Given this list of marker genes WDR24, PLEKHG1, SLX9, RNF111, PLEKHG3, RASA1, UBE3A, RNF115 (ring finger protein 115), H3C4, DCAF17, BRAF, STK26, C2CD3, ARMC7, EMP3, CTDSP2, ADNP, RASGRP2, ABRAXAS2, CTPS2, UNKL, HYCC1, SORL1, KIF3B, ACAP2, SLC2A9, SNRK, PAN2, ARL8B, PGM2L1, PRPSAP1, KRR1, CASP2, PLOD3, PKNOX1, PDE8A, PKN2, HMG20A, SORD, GPR160, TACC1, IKBKE, NFKB1, NKAPD1, ZCCHC8, NAA16, SLC29A3, LATS2, CMPK1, MRPS31, MSANTD4, MON2, TERF2, ATXN7L3B (NCBI Gene Id 552889), WLS, PIAS3, ALAS1, AGFG1, VIRMA, TMEM245, KHDC4, RNF216, ABHD14B, BRWD3, SREK1, CD300LB, HIPK3, PKD2, ERLIN2, NEK7, MAST3, RELCH, PREX1, MST1R, RERE, DENND5A, MFAP1, HEATR5B, CCDC71L, CYFIP1, PGD, SRCAP, ASH1L, HMGXB4 (HMG-box containing 4), IQGAP2, ZNF414, ANKRD40, MINDY1, DEPTOR, TTI2, TTC14, RSRC1, APP, KLHDC10, PLEKHH3, TPM3, ZBTB5, KDM5D, MYO7A, APPL2, SEPTIN11, G3BP2, ABCD3, HPSE, MCUR1 (mitochondrial calcium uniporter regulator 1), INTS6L, CCDC88C, DEGS1, TAF6, ZNF426, SVIL, GNPDA1, ATG4C, DCLRE1A, C2orf68, ATG13, AP1AR, PELI2, SOCS6, ATP10D, EDEM3, RREB1, TIFAB, TUBGCP5, RAB3D, SPECC1, RASSF4, EVI5, RAB33B, ZSCAN12, MCEMP1, CRYBG3, F10, SLX4, SLC25A30, RWDD4, CHML, GPATCH1, FAM217B, CELF2, PRAM1, NEK9, GTDC1 (NCBI Gene Id 79712), SMAD5, CX3CR1, ZBTB24, NCF1, TRAF3, DNAJC13, B3GNT8 (UDP-GlcNAc:betaGal beta-1,3-N-acetylglucosaminyltransferase 8), GALC (galactosylceramidase), RBM41, CNPY4, CGAS, PCYOX1, RBL2, CDK17, TMEM69, CD300LG, ANXA11, SYK, TSN, DOCK1 (NCBI Gene Id 1793), ZNF526, ZFP36L2, FAM8A1, TEPSIN, ZNF202, KLHL24, TCEANC2, KBTBD2, GALNT9, C5orf22, TRIM33, ZSWIM3, CCDC77, ENTPD7, MRPL3, ARMCX4, RAF1, ABHD17C, AMPD2, TPP1, HIP1, PCYT1A, PLEKHM3, SLC25A44, ZKSCAN8, TNRC6B, MRPL33, MED22, TMEM170B, GSPT2, ZFYVE21, RAP1GAP2, C6orf62, DHRS7, EVI2B, KCTD3, UMAD1, here is a description of the gene set: Human Gene Set: GSE29164_CD8_TCELL_VS_CD8_TCELL_AND_IL12_TREATED_MELANOMA_DAY7_UP Genes up-regulated in B16 melanoma at day 7 of adoptive transfer treatment: mock versus therapy. studied in species Homo sapiens Myeloid-derived cells comprising the tumor stroma represent a heterogeneous population of cells critical to the structure, function and growth of established cancers. We have recently found that engineering tumor-specific CD8+ T cells to secrete IL-12 (IL-12TD) can lead to striking improvements in T-cell activity against established melanomas in murine models. Surprisingly, IL-12-dependent enhancement of CD8+ T-cell anti-tumor function did not occur through direct ligation of receptors on lymphocytes or NK cells. Instead, IL-12 sensitized host bone marrow-derived tumor-stromal cells, partly through interferon-gamma, to indirectly enhance the effects of adoptively-transferred T cells. Direct presentation of antigen by tumor was not necessary, but MHC class I expression on endogenous cells was essential for IL-12 mediated anti-tumor enhancements. Upon successful treatment with IL-12TD cells, we observed the selective elimination of tumor-infiltrating CD11b+ F4/80+ macrophages, CD11b+/ClassII+/CD11c+ dendritic cells and CD11b+/Ly6C+/Ly6G- but not CD11b+/Ly6C+/Ly6G+ myeloid-derived suppressor cells within regressing lesions. These results are consistent with a model whereby IL-12 triggers the maturation of myeloid-derived cells into competent antigen cross-presenting cells. Licensed recognition of these antigens by effector T cells may in turn trigger the collapse of the tumor stroma and aid in the regression of large vascularized lesions. from publication Kerkar SP, Goldszmid RS, Muranski P, Chinnasamy D, Yu Z, Reger RN, Leonardi AJ, Morgan RA, Wang E, Marincola FM, Trinchieri G, Rosenberg SA, Restifo NP (PMID 22056381)